Given this list of marker genes Slamf1 (signaling lymphocytic activation molecule family member 1), Vsir, Tbx21, Lilrb4a, Foxp3, Ifnb1, Lilrb4b, Smad7, Arg1, Hfe, here is a description of the gene set: Any process that stops, prevents, or reduces the frequency, rate, or extent of T cell cytokine production. Mouse Gene Set: GOBP_NEGATIVE_REGULATION_OF_T_CELL_CYTOKINE_PRODUCTION studied in species Mus musculus